Given this list of marker genes EZR, HVCN1, TCL1A, FCRL1, POU2F2, TMEM154, PKIG, HIP1R, PPM1K, BANK1, RPS5, STX7, PLEKHF2, IRF8, ZBTB20, DUSP22, LBH, EBF1, SEMA4B, RPLP0, CDCA7L, TXNIP, DRAM2, BLNK, BACH2 (BTB domain and CNC homolog 2), GUCD1, FCER2, ATP2A3, CHPT1, KIAA0040, PDLIM1, MBD4, HSH2D (NCBI Gene Id 84941), EEF2, NCF1, CD74, VPREB3, CD79B, BCL11A, STAP1, BLOC1S2, MEF2C, DAPP1, CD79A, CD19, CD40, RCSD1, BTLA, ARID5B, NUP88, FCRLA, FCRL2, RPL18, GNG7, SNX22, BLK, P2RY10, CD200, NIBAN3, CXCR4, FAM3C, RALGPS2, BIRC3, SEL1L3, CXCR5, KLHL5, POU2AF1, TSPAN13, PLAC8, NAPSB, NCOA3, ORAI2, PLCG2, CYB561A3, MARCHF1, TPD52, LAPTM5, IKZF3, AFF3, RRAS2, SNX2, SMC6, RPS23, SWAP70, ZCCHC7, SELL, TRAF5, RPL8, CD52, TLE1, POLD4, RASGRP3, LINC00926, TMT1A (thiol methyltransferase 1A), CAMK1D, IL4R, FCMR, CD180, SESN1, SP100, QRSL1, ARHGAP24 (NCBI Gene Id 83478), SMCHD1, CLECL1P (NCBI Gene Id 160365), C16orf74, STRBP, SCIMP, ST6GAL1, SP110, PTPN6, CCR7, SMIM14, OSBPL10, SYPL1, BCL7A, ADAM19 (ADAM metallopeptidase domain 19), PNOC, TLR10, FCGR2B, RB1, PAX5, CD37, CHMP7, IFT57, LY86, LINC01215, CD72, PRKCB, FGD2, EAF2, ELOVL5, P2RX5, ITSN2, TNFRSF13C, GGA2 (golgi associated, gamma adaptin ear containing, ARF binding protein 2), TCF4, CD22, PARP1, CAMK2D, LIMD2, ADK, CD24, HHEX, RPL15, TNFRSF13B, ADAM28, CCDC50, SPIB, SP140, MYCBP2, TMEM243, TMEM156, MS4A1, RASGRP2, CXXC5, here is a description of the gene set: studied in species Homo sapiens Human Gene Set: TRAVAGLINI_LUNG_B_CELL from publication Travaglini KJ, Nabhan AN, Penland L, Sinha R, Gillich A, Sit RV, Chang S, Conley SD, Mori Y, Seita J, Berry GJ, Shrager JB, Metzger RJ, Kuo CS, Neff N, Weissman IL, Quake SR, Krasnow MA (PMID 33208946)